The following is a description of a gene set: species: Mus musculus Mouse Gene Set: GOBP_CELL_SURFACE_RECEPTOR_PROTEIN_TYROSINE_KINASE_SIGNALING_PATHWAY The series of molecular signals initiated by an extracellular ligand binding to a receptor on the surface of the target cell where the receptor possesses tyrosine kinase activity, and ending with the regulation of a downstream cellular process, e.g. transcription., and this is the list of marker genes: C1qtnf12, Fstl4, Pik3r1, Shc3, 2610005L07Rik, Ccdc88a, Irs1, Prkd1, Ceacam1, Cbl, Gkap1, Insr, Gpc1, Pdpk1, Sh2d3c, Nck1, Fgf18, Ahi1, Hap1, Epha10, Stat3, A1bg, Nherf1, Rassf2, Tgfa, Ephb2, Mmp14, Efna2, Wnt1, Grb10 (growth factor receptor bound protein 10), Rbpj, Gsk3a, Slc9a6, Ptk6, Ccbe1 (collagen and calcium binding EGF domains 1), Nrg2, Tmem204, Ptpre, Sh2b2, Myorg, Myoc, Ngf, Mup5, Fgfrl1, Ngef, Sorl1, Axl, Rhbdf1, Alkal1, Cav2, Ngfr, Wnt4, Phf14, Flt3, Socs4, Nrp2, Ntf5, Cblb (NCBI Gene Id 208650), Ptp4a3, Cripto, Jcad, Ins1, Caml, Prickle1, Ptprf, Nedd4, Fgf4, Abl1, Ntf3, Stap1, Plekha1, Serpina12, Adipor1 (adiponectin receptor 1), Epha8, Il12a, Cadm4, Tbx2, Efnb2, Gigyf1, Fgf5, Tsc2, Rtn4, Col4a2, Mst1r, Igfbp3, Obp2a, Lrp1, Agr2 (NCBI Gene Id 23795), Sema6a, Dok3, Csf1r, Smoc2, Sgpl1, Prkaa1, Neu3, Pik3r3, Epha3, Akt1s1, Ndn, Socs1, Fzd4, Dstyk, Adipoq, Angpt4, Rapgef2, Cdh3, Col6a1, Bmp4, Shkbp1, Dok2, Fgf12, Ddr2, Agtr2, Col4a6, Cyfip1, Klb, Mertk, Srsf3, Src, Map2k2, Churc1, Ephb6 (Eph receptor B6), Ghrhr, Flrt3, Apod, Arf4, Ext1, Ret, Epha7, Fgfr1, Vtn, Gfra1, Sik2, Fasl, Hip1, Mup4, Diaph2, Fgf1, Sh3tc2, Spry2, Ston1, Fgf21, Bmp2, Gfra3, Irs3, Gigyf2, Hras, Efna5, Slc2a8, Atxn7, Anks1, Myo1c, Enpp1, Zbtb7b, Mvb12b, Fgf3, Kank1, Angpt1, Ror2, Erbb3, Shc4, Yes1, Ephb4, Rapgef1, Psen2, Fgf6, Zfp640, Sulf1, Atp1a3, Chrd, Syk, Grb2, Iqgap1, Mup1, Socs7, Gper1, Pdgfc, Fshr, Chn1, Gdf15, Itga1, Sos2, Sox9, Lat, Sh3glb1, Epha5, Lep, Prkcb, Lyn, Pip4k2b, Ulk1, Mup3, Casp3, Irs4, Lonp1 (lon peptidase 1, mitochondrial), Stat6, Rps6kb2, Afap1l2, Snx5, Nog, Tradd, Fgf17, Prkca (NCBI Gene Id 18750), Cep57, Ghsr, Zfp592, Acp4, Ptpn2, Alk, Zdhhc16, Ift88 (intraflagellar transport 88), Sort1, Mir494, Fgf22, Ntrk2, Pdgfra, Myo1e, Rarres2, Esm1, Bex1, Dab2ip, Pten, Foxo4, Srebf1, Foxc2, Ralb, Tiparp, Ffar3, Zgpat, Plce1, Irs2, Sh2d6, Ubash3b, Fbxw8, Hmga1, Stat5a, Igfbp6, Notch1, Zfyve28, Zdhhc17, Ahsg, Plat (NCBI Gene Id 51950), Rbx1, Fgfr4, Nrtn, Dbx2, Fgf16, Efs, Rala, Rabgef1, Epha2, Itgb1, Jak2, Atxn1 (ataxin 1), Hhip, Diaph1, Pdcd6, Ptpra, Mmrn1, Blvra, Erbb2, Sorbs1, Akt1, Inppl1, Mapk3, Fgf14 (NCBI Gene Id 14169), Robo1, Ss18, Fam20c, Mvb12a, Mapk1, Plcg1, Tiam1, Ceacam2, Chmp6, Ror1, Stxbp4, Ogt, Gpr21, Sh2b3, Csrnp1 (NCBI Gene Id 215418), Alkal2, Csrp3, Psen1, Egfr, Ide, Nup62 (NCBI Gene Id 52394), Trim72, Ephb1, Hspb1, Esr1 (NCBI Gene Id 13982), Tom1l1, Prkcq, Fam83b, Prlr, Grb7, Mvp, Fgf7, Emilin1, Zfand5, Nkx3-1, Fgf8, Pou1f1, Trim71, Shcbp1, Hrg, Igf2, F3, Slc27a4 (solute carrier family 27 (fatty acid transporter), member 4), Txnip (thioredoxin interacting protein), Igf1, Fgf9, Adamts3 (ADAM metallopeptidase with thrombospondin type 1 motif 3), Vegfc, Zfp106, Rnf115, Ptgir, Flrt1, Ncoa5, Cdk5r1, Lck, Gata3 (GATA binding protein 3), Dok6, Fgfbp3, Smpd3, Ereg, Fgf2, Ofd1, Tgfb1, Mbd5, Blvrb, Dgkd, Ptpn1, Agt, Mir143, Cpne3, Muc20, Efnb3, Nck2, Hck, Kl, Ccn2, Gfra4, Dcn, Pxn, Slc39a14, Csf1, Tmem108, Ppp2r5b, Errfi1, Ift80, Hbegf, Mup11, Opa1, Tns2, Grb14, Fgf15, Lrig2, Insrr, Flt4, Plcb1, Il1b, Adam10, Ankrd26, Ptprj, Abl2, Jak3, Pik3cd, Frk, F7, Mtcl2, Fgfr2, Srms, Kif16b, Pik3ca, Il12b, Hgs (HGF-regulated tyrosine kinase substrate), Map2k1, Smarcc1, Cd63, Zfyve27, Frs3, Mapk14, Marcks, Igf1r, Hif1an, Mfn2, Itgb3, Vil1, Lrit3 (NCBI Gene Id 242235), Epgn, Eif2ak3, Rhod (NCBI Gene Id 11854), Mep1a, Ptpn11, Ift20, Ercc1, Ptk2, Hgf, Ptk2b, Col1a1, Blk, Rhoq, Adrm1, Pdgfa, Ltk, Nrg4, Mmp9, Adgrg1, Fgf23, Adamts12, Npr2, Lcp2 (NCBI Gene Id 16822), Rela, Gsk3b, Egf, Gdnf, Pik3r2, Nucks1, Bdnf, Tyro3, Clasp2, Tsg101, Fgr, Vegfa, Pdgfd (NCBI Gene Id 71785), Fgfr3, Spg21, Sulf2 (sulfatase 2), Socs5, Nrg3, Flt1, Blnk, Ptpn12, Spry4, Musk, Chrna3, Phip, Areg, Pgf (NCBI Gene Id 18654), Nfatc4, Adgre4, Nr1h4, Pip4k2c, Lmtk2, Clec14a, Ptprt, Nptn, Spry1, Pde6h, Tie1, Vps25, Sipa1l1, Erfe, Igfbp2, Creb3l1, Samd12, Prdm14, Mup2, Pigr, Ddit4, Pdk4, Wasf1, Gp6, Myocd, Gprc5a, Ddr1, Efnb1, Col4a3, Akt2, Angpt2, Pde6g, Igfbp1, Nrg1, Ercc2, Fer, Ar, Rgs14, Leprot, Samd10, Apc, Xbp1, Inpp5k, Gab1, Sirt1, Jak1, Sos1, Efemp1, Rnf126 (ring finger protein 126), Slc31a1, Cass4, Foxc1, Mcemp1, Ephb3, Fyn, Ctnnb1, Epha4, Gfra2, Slc30a10, Xdh, Efna4, Nppa, Flrt2, Fam83a, Anks1b, Ccl2, Cnmd (NCBI Gene Id 16840), Hip1r, Pid1, Fuz, Ghr, Stat5b, Kras, Fut7, Ryk, Prkcd, Myof, Garem1, Prkd2, Vegfd, Ptprr, Svep1, Rac1, Apln, Braf, Hif1a, Ins2, Appl1, Nedd9, Cilp, Cul7, Gpld1, Shisa2, Met, Pik3cb, Wnt5a, Raf1, Bace1, Ppp2r5d, Pak1, Fat4 (NCBI Gene Id 329628), Runx2, Cspg4, Frs2, Socs2, Socs3, Dok1, Mmrn2, Gfral, Zfand2b, Hhex (hematopoietically expressed homeobox), Gab2, Ndst1, Schip1, Btc, Tspan9, Cadm1, Pdgfb (platelet derived growth factor, B polypeptide), Vegfb, Fgfbp1, Adam17, Epha1, Ncl, Adgra2, Rab7, Adra2a, Eif4ebp1, Itga5, Clnk, Gh, Foxo1, Thbs1, Gnai2, Plaur, Cyfip2, Rab14, Nus1, Nrp1, Fgf20, Ntrk3, Tnf, Snca, Tek, Efna3, Stmn1 (NCBI Gene Id 16765), Vwa2, Cd2ap, Mzb1, Wdr54, Shc2, Osbpl8, Epn2, Pip4k2a, Epha6, Zfp950, Tyk2 (NCBI Gene Id 54721), Bcar1, Angptl1, Rbm4, Erbb4, Dok4, Lgmn, Nrxn1, Pdgfrb, Kit, Leprotl1, Mstn, Col4a5, Lox, Artn, Kdr, Sesn3, Crkl, Igfbp5, Eif4ebp2, Rps6kb1, Pspn, Shc1, Map2k5, C2cd5, Vps13a, Mapkapk2, Tfap2a, Ros1, Slc2a4, Ndrg4, Pdk2, Tcf4, Igfbp4, Prkcz (protein kinase C, zeta), Klk8, Cd59a, Dnai1, Nucb2, Dusp3, Bmp5, Cblc, Ntrk1, Ndel1, Col4a1, Cdh13, Rhbdf2, Nr4a3, Tspan32, Dok5, Crk, Bcr, Esr2, Ctsd, Bcar3, Arid5b, Mt3, Mir875, Pdap1, Fgf10, Tcf7l2, Dll1, Efna1, Cnot9, Git1